The following is a description of a gene set: from publication Marigo I, Bosio E, Solito S, Mesa C, Fernandez A, Dolcetti L, Ugel S, Sonda N, Bicciato S, Falisi E, Calabrese F, Basso G, Zanovello P, Cozzi E, Mandruzzato S, Bronte V (PMID 20605485) Genes down-regulated in CD11b+ from spleen of healthy C57BL6 versus CD11b+ cells from tumors of C57BL6 mice bearing EL4 lymphoma. Tumor growth is associated with a profound alteration of myelopoiesis, leading to recruitment of immunosuppressive cells known as myeloid-derived suppressor cells (MDSCs). Analyzing the cytokines affecting myelo-monocytic differentiation produced by various experimental tumors, we found that GM-CSF, G-CSF, and IL-6 allowed a rapid generation of MDSCs from precursors present in mouse and human bone marrow (BM). BM-MDSCs induced by GM-CSF+IL-6 possessed the highest tolerogenic activity, as revealed by the ability to impair the priming of IFN- -producing CD8+ T cells upon in vivo adoptive transfer. Moreover, adoptive transfer of syngeneic, GM-CSF+IL-6-conditioned MDSCs to diabetic mice transplanted with allogeneic pancreatic islets resulted in long term acceptance of the allograft and correction of the diabetic status. Cytokines inducing MDSCs acted on a common molecular pathway. Immunoregulatory activity of both tumor-induced and BM-derived MDSCs was entirely dependent on C/EBP transcription factor, a key component of the emergency myelopoiesis triggered by stress and inflammation. Adoptive transfer of tumor antigen-specific CD8+ T lymphocytes resulted in therapy of established tumors only in mice lacking C/EBP in myeloid compartment. These data unveil another link between inflammation and cancer and identify a novel molecular target to control tumor-induced immune suppression. We used gene expression analysis to identify those factors, secreted by tumor-infiltrating MDSC, which could drive emathopoiesis. Moreover we compare gene expression profile of tumor-induced MDSC, obtained from either the spleen and the tumor infiltrate of tumor bearing mice, and in vitro bone marrow-derived MDSC. Human Gene Set: GSE21927_SPLEEN_C57BL6_VS_EL4_TUMOR_BALBC_MONOCYTES_DN studied in species Homo sapiens, and this is the list of marker genes: TIMM8B, UQCRQ, ATG101, PDCD11, NDUFS1, EIF3J, SLBP, CTNNAL1, MORF4L2, RFC2, RAC1, NUP188, HSPA9, RARS1, ERH, SEC61B, HNRNPD, NAT10, MAPKAPK3, SMC4, RWDD2B, KIF18A, AFG3L2, MCM7, NDUFB6, NHP2, DLD, ALG3, SKIC8, POLD2, R3HDM1 (NCBI Gene Id 23518), NOC2L, TTLL12 (tubulin tyrosine ligase like 12), SNRPF, COX8A, CFAP20, EIF3B, CIT (citron rho-interacting serine/threonine kinase), MRPL34, PSME2, HMGB3, GSPT1, NSMCE4A, AATF, DCPS, DDX56, MRPS14, SERPINE2, CCDC85B, PPM1G, FANCL, UTP14A, IPO5, BYSL, DKC1 (NCBI Gene Id 1736), IARS2, RNF25, EGR2, AIRIM, BUD31, ZNF706, PMAIP1, DDX49, EIF3A, UQCRH, HILPDA, PMM2, PSAT1, CLPX, ATAD2, ORC6, SH2B3, PSME3, HCFC1, GRPEL1, DPH2, VCAM1, GINS3, SEM1, CSNK2A1, PSMA7, PPAT, PHGDH, KIF15, THOC5, LSM4, CLPB, PMPCA, UBE2L3, CASP3, DDX21, ETFB, EPRS1, MRPS12, RPSA (ribosomal protein SA), IFRD2, MIF, ALG8, POLDIP2, NUP88, MRPL40, MTHFD2L, GADD45GIP1, NUDC, UBE2S, SNRPE, FKBP4, CCND2, UTP18, POLR2H, PSMD8, MNAT1, ITGB3BP, HSBP1, POLR2I (NCBI Gene Id 5438), UBA5, STX18, NASP, RTCB, MRPS18A, HK2, HSPA8, YBX1, PDAP1, ANAPC10, NXT1, MRPL52, E2F8, CLUH, MED20 (NCBI Gene Id 9477), POLR2D, MMADHC, DPP3, PRPF19, POLR2E, FASTKD3, URB2, NEIL3, GTF2H4, RAB11A, XRCC6, ZWILCH, NAPG, WARS1, DNTTIP2, DESI2, ALDOA, CLTA, MOB4, NABP2, BLVRA, POP1, ECD, EIF4G2, TUBA3D, GRSF1, PWP1, MRPS30, WDR77, PDIA4, TUBG1, CRELD2, MYL6B, RAB8B (RAB8B, member RAS oncogene family), DNAAF2, RPP30, GTPBP4, CHUK, NFKB1, BHLHE40, HPF1, GNL2, ABCF1, STOML2, JPT2, TOE1, DEF8, SOCS1, SERBP1, MCM4, SLC25A11, CMC2, ODC1, MTREX, PSMG1, TMEM11, CALU, SNRNP40, HMGA1, STAM, SKA1, DNAJC2, PRIM1, IL18R1, APOOL, MRPS2, EMG1, CISD1, PARP2 (poly(ADP-ribose) polymerase 2), SLC7A5